Given this list of marker genes Opn1sw, Onecut2, Krba1 (NCBI Gene Id 77827), Garem1, Terf1, Lsm11, Gna11, Golph3, Mfap1b, Mospd1, Mfap1a (microfibrillar-associated protein 1A), Gm11780, Stag1, Rsrc2, Hipk1, Sprr2b, Slc66a2, Adam17, Usp33 (ubiquitin specific peptidase 33), Egr2, Kif26b, Sp1, Celf3, Tmem71, Nrp1, Rps6kb1, Set, Rnf214, Upf2, Hoxb3, Nup133, Dclk1, Zdhhc21, Bivm, Dlg3, Calu, Mthfsl, Pbx1, Vegfc, Zfp654, Enpep, Rin2, Tbc1d30 (NCBI Gene Id 77450), Map4k5, Aqp8, H2-Aa, Rap1a, Kmt2c, Bpnt1, Bach2, Srrm1, Cdk13, Lpp, Aass, Fat3, Ccnt2, Tada2b, Ctnnd1, Hmcn1, Usp4, Fam234b, Fbxo8, Cacna1b, Tmem33, Tbc1d10a (NCBI Gene Id 103724), Dpp10, Dab2, Ppp1r3a, Pgm3, Ccna2, Ppp1ca, Cpeb4, Dmd, Syk, Ptpre, Daam1, Med21, Mindy2, Eddm3b, Tmcc3, Tlr5, Trhde, Txndc5, Map3k2, Nabp1, Rufy3, Bhlhe41, N4bp2l2, Cdh11, Syncrip, Slc25a13, Abhd14b, Frs2, Ttbk2 (tau tubulin kinase 2), Impg2, Mthfs, Jag1, Bpifb2, Mllt3, Lypd6, Itm2a, Bicd2 (BICD cargo adaptor 2), Rbm39, Kdelr1, Rab39 (RAB39, member RAS oncogene family), Depdc1a, Zfp41, Hnrnpa1, here is a description of the gene set: species: Mus musculus Genes predicted to be targets of miRBase v22 microRNA mmu_miR_7646_5p in miRDB v6.0 with MirTarget v4 prediction scores > 80 (high confidence targets). Mouse Gene Set: MIR_7646_5P from publication Chen Y, Wang X (PMID 31504780)